The following is a description of a gene set: species: Mus musculus Mouse Gene Set: GOBP_NEGATIVE_REGULATION_OF_RECEPTOR_RECYCLING Any process that stops, prevents, or reduces the rate of receptor recycling., and this is the list of marker genes: Trat1, Pcsk9, Ldlr, Ap1ar, Optn